Given this list of marker genes KMT2C, H2AJ, H2AC18, NFE2L2, H2BC12, EPAS1, MYC, H2AB1, H2BC14, H2BC11, H2BC21, H3C1, TEAD3, NFKB2, CTNNB1 (catenin beta 1), FOS, FOSB, RBBP7, H2AC14, RBBP5 (RB binding protein 5, histone lysine methyltransferase complex subunit), H2AZ2, STAT1, TCF7, WWTR1, H3C15, TCF7L2, TEAD4, H2BC5, H2AC7, H2AX, BRD4, ATF3, H2BC9, TCF7L1, H2AC6, ASH2L, STAT3, H2BC17, DPY30, RELA, H2BC4, JUND, YAP1, LEF1, H2BC13, H2AC20, H2BC12L, NFKB1, MYCN, TEAD2, IRF1, H2BC26, H4C1, TEAD1, RBBP4, SUZ12, KMT2A, EP300, CREBBP, CD274, EED, H2BC1, H2BC3, H2BC15, HIF1A, WDR5, EZH2, H3-3A, JUN, H2AC4, here is a description of the gene set: studied in species Homo sapiens Reactome Pathway: Regulation of PD-L1(CD274) transcription The transcriptional regulation of CD274 (PD-L1/ programmed death-ligand 1) plays a critical role in the regulation of normal T cell function in normal physiological condition where it provides immune homeostasis. The expression of PD-L1 is tightly controlled by various transcription factors and signalling pathways, which respond to both intrinsic cellular signals and extrinsic environmental perturbations. PD-L1 is regulated transcriptionally by multiple mechanism like epigenetic modifications (EZH2, DNMTs, MLLs), transcription factors (STAT3. STAT1, IRF1, MYC, HIF and ither) which get activated in response to multiple upstream signalling pathways. The transcriptional regulation of PD-L1 is a complex interplay of oncogenic signalling pathways, cytokine responses, epigenetic modifications, specific transcription factors, the tumour microenvironment, and non-coding RNAs. This multifaceted regulation ensures that PD-L1 expression can be finely tuned to promote immunotolerance in normal condition as well as immune evasion in cancer, making it a critical target for cancer immunotherapy (Zhou et al.,2023, Cha et al.,2019, Yamaguchi et al.,2022, Ju et al.,2020) part of: Regulation of PD-L1(CD274) expression